Given this list of marker genes Nfatc2, Smim3, Fam20a, Hsd17b8, Pnma8b, Stk4, Tirap, Ankrd54, Slc22a27, Fam168a, Btrc, Add2, Tspan15, Bbs1, Raly, Akirin2, Dkk3, Lad1, Zfp830, Trim44, Plcb2, Tom1l2, Nutf2, Tmem253, Atosb, Ypel5, Psenen, Exd2 (exonuclease 3'-5' domain containing 2), Mtf1 (metal response element binding transcription factor 1), Sgpp2, Dagla, Rpp14, Hcar1, Ccdc92b, Bend3, Rnf216, Aifm3, Ahcyl2, Scube1, Chrm1, St3gal1, Csf1, Sec24c, Myocd, Gdap2, Shisa7, Gata4, Extl3, Btg2, Tmtc3, Khdrbs1, Smpd3, Dll3, Zfp202, 2510039O18Rik, Col9a1, Pou6f1, Hgh1, Mnt, Itpr3, Scmh1, Washc4, Tanc2 (tetratricopeptide repeat, ankyrin repeat and coiled-coil containing 2), Krtap9-3, Icmt, Celsr2, Trim67, Ifit1, Atxn7l3, Dcaf8, Cnot9, Ccdc127, Hip1, Ntsr1, Sulf1, Clip3, Kbtbd2, Hpcal4, Ppp2r3d, Samhd1, Trim35, Tmem167, Setd1b, Cd34, Csnk1g1, Nacc1, Man1b1, Wnt5a, Rhbdl3, C2cd4c, Cyp2c68, Celsr3, Btf3l4, Foxj1, Arrb1, Sdc3, Dlgap3, Vps39, Lrrc8a, Rab3d, Mymk, C2cd2l, Adam1b, Hs3st3b1, Mtor, Ammecr1, Prrg3, Ldlrap1, Tmem104, Hycc2, Tnfsf4, Tek, Nrf1, Ube2e1, Myadml2, Bcl9, Fam131b, E130308A19Rik, H2-Oa, Adra2b, Gata2, Rce1, Dvl3, Ceacam12 (NCBI Gene Id 67315), Tppp, Phlda1, S1pr3, Lrrc56, Phf24, Adal, Slain2, Rcor1, here is a description of the gene set: species: Mus musculus Mouse Gene Set: MIR_3474 Genes predicted to be targets of miRBase v22 microRNA mmu_miR_3474 in miRDB v6.0 with MirTarget v4 prediction scores > 80 (high confidence targets). from publication Chen Y, Wang X (PMID 31504780)